The following is a description of a gene set: from publication Abdelmohsen K, Hutchison ER, Lee EK, Kuwano Y, Kim MM, Masuda K, Srikantan S, Subaran SS, Marasa BS, Mattson MP, Gorospe M (PMID 20584986) Major ELAVL4 associated mRNAs encoding proteins with functions in neuronal physiology. Human Gene Set: ABDELMOHSEN_ELAVL4_TARGETS Neuronal development and plasticity are maintained by tightly regulated gene expression programs. Here, we report that the developmentally regulated microRNA miR-375 affects dendrite formation and maintenance. miR-375 overexpression in mouse hippocampus potently reduced dendrite density. We identified the predominantly neuronal RNA-binding protein HuD as a key effector of miR-375 influence on dendrite maintenance. Heterologous reporter analysis verified that miR-375 repressed HuD expression through a specific, evolutionarily conserved site on the HuD 3' untranslated region. miR-375 overexpression lowered both HuD mRNA stability and translation and recapitulated the effects of HuD silencing, which reduced the levels of target proteins with key functions in neuronal signaling and cytoskeleton organization (N-cadherin, PSD-95, RhoA, NCAM1, and integrin alpha1). Moreover, the increase in neurite outgrowth after brain-derived neurotrophic factor (BDNF) treatment was diminished by miR-375 overexpression; this effect was rescued by reexpression of miR-375-refractory HuD. Our findings indicate that miR-375 modulates neuronal HuD expression and function, in turn affecting dendrite abundance. species: Homo sapiens, and this is the list of marker genes: CASP3, KCNQ2, ITGA1, LEPROTL1, PARP1, DLG4, ITGB1, CDH2, KMT5A, BCL2, NCAM1, RAB10, CDC42, RHOA, EIF2AK2, CAB39